The following is a description of a gene set: Mouse Gene Set: GOBP_LIPID_TRANSPORT_ACROSS_BLOOD_BRAIN_BARRIER species: Mus musculus The directed movement of lipid molecules passing through the blood-brain barrier., and this is the list of marker genes: Apoe, Fabp5, Mfsd2a, Slc27a4 (NCBI Gene Id 99453), Slc27a1, Cd36